The following is a description of a gene set: Human Gene Set: GOBP_ATRIAL_SEPTUM_DEVELOPMENT The progression of the atrial septum over time, from its initial formation to the mature structure. studied in species Homo sapiens, and this is the list of marker genes: SMO, WNT5A, MDM4, TBX5, MDM2, TGFB2 (NCBI Gene Id 7042), ISL1, NOTCH2 (NCBI Gene Id 55574), BMPR2, TBX20, SOX4, ANK2, NPHP3, HEY2, NSD2, NKX2-5, CCN1, GJA5, ZFPM1, GATA4, DAND5, WNT11, ACVR1